Given this list of marker genes Specc1, Dpysl5, Hsh2d, Flot2, Gap43, Nmnat2, Alyreffm10, Igf1r, Ptbp2, Nr1d1, Ctbs, Ctr9, Dcaf8l, Cdc27 (NCBI Gene Id 268493), Thra, Rgs7bp, Bsn, Anks1, Hook3, Cd86, Alyreffm11, 4921536K21Rik, Atf6b (activating transcription factor 6 beta, NCBI Gene Id 54136), Zbtb45, Ark2c, Gstz1, Eif4ebp2, Alyreffm15, Zmym3, Plagl1, Phactr2, Clvs1, Prkar2b, Eif4b, Cd200l1, Snx27, Prickle2, Prxl2a, Fbxl17, 0610030E20Rik, Fignl2, B4galt1, Fchsd2, Plxna2, Nt5dc3, Col11a1, Gcnt1, Tmem79, Tmem141, Fam222b, Pth, Wdtc1, Vegfa, Rab14, Ctnnd1, Ifi213, Slc16a14, Trim23, Nid1, Ncs1, Synj2bp, Usp17la, Ptpn14 (NCBI Gene Id 226829), Arid1a, Xkr4, Adgrb1, Rab5b, Igf1, Dapp1, Gsx1, Carmil1, Socs3, Tenm2, Myadm, Zfp385a (NCBI Gene Id 29813), Tfcp2l1, Dgkk, Alyreffm17, Baz2a, Alyreffm13, Pcnp, Alyreffm14, Rnf13, Srcap, Ppp6r1, Hoxb9, Alyreffm16, Exd2, Anxa2, Klf3, Ckmt2, Zdhhc9, Luzp1, Ost4, Sptb, Rgs5, Tpst2, Tnip3, Hyls1, Zfp169, Pak2, Coro1c, Prr3, St6galnac3, Tspan18, Sec14l3, Phlpp2, Sv2c (NCBI Gene Id 75209), here is a description of the gene set: Genes predicted to be targets of miRBase v22 microRNA mmu_miR_8119 in miRDB v6.0 with MirTarget v4 prediction scores > 80 (high confidence targets). Mouse Gene Set: MIR_8119 studied in species Mus musculus from publication Chen Y, Wang X (PMID 31504780)